Given this list of marker genes MYC, TFAP2A, KDM5B, TFAP2C, CDKN1A, here is a description of the gene set: TFAP2A and TFAP2C play opposing roles in transcriptional regulation of the CDKN1A (p21) gene locus. While TFAP2A stimulates transcription of the CDKN1A cyclin-dependent kinase inhibitor, TFAP2C, in cooperation with MYC and histone demethylase KDM5B, represses CDKN1A transcription. part of: Transcriptional regulation by the AP-2 (TFAP2) family of transcription factors species: Homo sapiens Reactome Pathway: TFAP2 (AP-2) family regulates transcription of cell cycle factors